The following is a description of a gene set: Euryblepharon is a congenital eyelid anomaly characterized by horizontal enlargement of the palpebral fissure. The eyelid is shortened vertically compared with the horizontal dimension, with associated lateral canthal malpositioning and lateral ectropion abnormally wide lid opening. Human Gene Set: HP_EURYBLEPHARON Euryblepharon studied in species Homo sapiens, and this is the list of marker genes: ACTB, WNT5A, CTNND1, DLX4, CDH1, DVL1, ACTG1, DVL3, FZD2